Given this list of marker genes Nlrp1a, Mapk11, Crip1, Mfap4, Nlrp1b, Mapk14, Bcl2, Stk11, Hyal1, Il12b, Ivl, Cdkn1a, Xpc, Ercc6, Rela, Mme, Hmgn1 (high mobility group nucleosomal binding domain 1), Il12a, Hyal2, Msh2, Hyal3, Map3k20, here is a description of the gene set: species: Mus musculus Mouse Gene Set: GOBP_RESPONSE_TO_UV_B Any process that results in a change in state or activity of a cell or an organism (in terms of movement, secretion, enzyme production, gene expression, etc.) as a result of a UV-B radiation stimulus. UV-B radiation (UV-B light) spans the wavelengths 280 to 315 nm.